Given this list of marker genes FAP, CLEC12B, TBX2, OR51E2, WNT5A, here is a description of the gene set: Human Gene Set: GOBP_MELANOCYTE_PROLIFERATION studied in species Homo sapiens The multiplication or reproduction of melanocytes, resulting in the expansion of a cell population. A melanocyte is a pigment cell derived from the neural crest. It contains melanin-filled pigment granules, which give a brown to black appearance.